Given this list of marker genes NFATC2, EYA3, NDN, LCOR, AIRE, PDX1, HOXA4, TCF21, ESRRB, ZNF235, SOX6, NR1I3, CRX, CACNA1A, HIC1, TFCP2L1, MEF2C, MEIS3, SOWAHC, SFRP4 (NCBI Gene Id 6424), EVX2, PIAS3, HNF4G, MYCL, HOXA6, here is a description of the gene set: Aberrant expression of the human homeobox-containing proto-oncogene TLX1/HOX11 inhibits hematopoietic differentiation programs in a number of murine model systems. Here, we report the establishment of a murine erythroid progenitor cell line, iEBHX1S-4, developmentally arrested by regulatable TLX1 expression. Extinction of TLX1 expression released the iEBHX1S-4 differentiation block, allowing erythropoietin-dependent acquisition of erythroid markers and hemoglobin synthesis. Coordinated activation of erythroid transcriptional networks integrated by the acetyltransferase co-activator CREB-binding protein (CBP) was suggested by bioinformatic analysis of the upstream regulatory regions of several conditionally induced iEBHX1S-4 gene sets. In accord with this notion, CBP-associated acetylation of GATA-1, an essential regulator of erythroid differentiation, increased concomitantly with TLX1 downregulation. Coimmunoprecipitation experiments and glutathione-S-transferase pull-down assays revealed that TLX1 directly binds to CBP, and confocal laser microscopy demonstrated that the two proteins partially colocalize at intranuclear sites in iEBHX1S-4 cells. Notably, the distribution of CBP in conditionally blocked iEBHX1S-4 cells partially overlapped with chromatin marked by a repressive histone methylation pattern, and downregulation of TLX1 coincided with exit of CBP from these heterochromatic regions. Thus, we propose that TLX1-mediated differentiation arrest may be achieved in part through a mechanism that involves redirection of CBP and/or its sequestration in repressive chromatin domains. Selected genes whose expression profile follows that of APOBEC2 in the TLX1 Tet On iEBHX15-4 cells (pro-erythroblasts). species: Mus musculus from publication Riz I, Akimov SS, Eaker SS, Baxter KK, Lee HJ, Mariño-Ramírez L, Landsman D, Hawley TS, Hawley RG (PMID 17213805) Human Gene Set: RIZ_ERYTHROID_DIFFERENTIATION_APOBEC2